Given this list of marker genes FGFR2, DYNC2LI1, SERPING1, FOXE1, PRRX1, FGFR3, SF3B4, KRT5, SETBP1, IFT80, KRT14, ASAH1, C2CD3, EIF4A3, FREM2, NEK1, DYNC2H1, DYNC2I1, WDR35, DYNC2I2, CILK1, FGF10, GLI3 (GLI family zinc finger 3), here is a description of the gene set: Human Gene Set: HP_ABNORMAL_EPIGLOTTIS_MORPHOLOGY Abnormal epiglottis morphology species: Homo sapiens An abnormality of the epiglottis.